Given this list of marker genes PI4KB, RPN1, SEC61G, PTGDS, STX17, RPL6, RP9, F12, VTN, RPL4, RANGRF, HM13, CA4, SEC62, TMCC1, PKM, MYOC, ARL6IP1, SEC61A1, TMEM97 (transmembrane protein 97), RPL18, SRPRB, PLOD3, PLOD1, LRAT, HCRT, ALG5, LRPAP1 (NCBI Gene Id 4043), RPL27, SYNE3, STAU1, MACO1, UBA1, SSR4, EPHA5, PSEN1, RPS23, SRP9, FKRP, HGFAC, SEC61B, CDKAL1, ZC3H12A, CCDC47, LIN28A, RAB14, EDN1, RPS21, GNRH1, RPS28, PLOD2, RPS29, RPS26, CKAP4 (cytoskeleton associated protein 4), SEC63 (SEC63 homolog, protein translocation regulator), SRPRA, EPM2A, SPPL3, SUCO, SEC61A2, here is a description of the gene set: Human Gene Set: GOCC_ROUGH_ENDOPLASMIC_RETICULUM species: Homo sapiens The rough (or granular) endoplasmic reticulum (ER) has ribosomes adhering to the outer surface; the ribosomes are the site of translation of the mRNA for those proteins which are either to be retained within the cisternae (ER-resident proteins), the proteins of the lysosomes, or the proteins destined for export from the cell. Glycoproteins undergo their initial glycosylation within the cisternae.